The following is a description of a gene set: Genes predicted to be targets of miRBase v22 microRNA mmu_miR_6407 in miRDB v6.0 with MirTarget v4 prediction scores > 80 (high confidence targets). Mouse Gene Set: MIR_6407 studied in species Mus musculus from publication Chen Y, Wang X (PMID 31504780), and this is the list of marker genes: C2cd4a, Zpld1, C8b, Tcf7, Zdhhc14, E130311K13Rik, Ndst1, Prnd, Pde7a, Adra2c, Reep4, Mdga2, Cwf19l2, C4b, Ankrd17, Gprc5c, Maneal, Klhl29, Fam185a, Sgms1, Ywhag, Stradb, Ago2, Hspe1, Ppp3r2, Gm5622, Znrf1, Lamtor5, Atp2b4, Slx9, Frmd5, Elmo2, Itpr2, Ccdc102a, Xylb, Sys1, Hdac9, Vwc2, Fam210b, Nwd1, Rnpepl1, 4930558K02Rik, Tbl1xr1, Stau1, Numbl, Naa11, Ctps2, Crlf3, Qpct, Cdan1, Sh3glb1, Gpatch8, Elk1, Slc9a9, Tmem266, Oprd1, Pex26, Aplf, Tada2b, Timm17b, Mpped2, Ralbp1, Acat1, Lrba, Prn, Kansl3, Stk33, Crat, Gm8267, Cnksr3, Srsf10, Adap1, Mau2, Nsf, Mtif3, Adamts2, Myrip, Slco5a1, Emp2, Fut9, Gemin8, Ifi27l2a, Slc38a10, Dnase1l3, Il24, Cep57l1, Clec2h (NCBI Gene Id 94071), Cacybp, Ctns, Pla2g12a, Gmps, C4a, Tafa5, F3